The following is a description of a gene set: Sorafenib is a first generation type II tyrosine kinase inhibitor with broad specificity for receptor tyrosine kinases including FLT3. This pathway describes FLT3 mutants that are resistant to sorafenib-mediated inhibition. Reactome Pathway: sorafenib-resistant FLT3 mutants part of: Drug resistance of FLT3 mutants studied in species Homo sapiens, and this is the list of marker genes: FLT3